Given this list of marker genes Mc4r, Zwint, Kif13a, Osmr, S100b, Serinc1 (serine incorporator 1, NCBI Gene Id 80452), Zfp704, Egflam, Copb1, Rcan2, Hhipl2, Grb2, Vti1a, Rhag, Fchsd1, Pafah1b1, Eif2ak4, Tnrc6a, Slc39a13, Hspa4l, Thsd7a, Actr1a, Med22, Mettl9, Atp5f1a, Tafa3, Alkbh5, Plaa, Arid1a, Ncbp3, Map3k9, Mapk6, Smdt1, Wtap, Raph1, Srsf2, Dnm1, Crtc1, Dis3l, Lhx3, Cabin1, Rbm27, Sh2d7, Ranbp10, Fndc10, Nsd2, Wdhd1, Tceal7, Tgm3, Pgbd5, Sstr1, Eif5, Slc25a42, Rtel1, D5Ertd579e (NCBI Gene Id 77811), Rccd1, Kcnk3, Cpt1a, Cdo1, Alx3, Cdh5, Mgat4a, Nol3, Tube1, Crebrf, Plxna1, Rubcn, Cant1, Ncor1, Frs3, Zeb2, Prr11, Lias, Vhl, Slc24a3, Shisal1, Ak1, Dgkg, Hivep3, Vcp, Gpatch4, Cdc26, Ndufa8, Krtap5-3, Trip12, Pde4d, Galnt16, Fkbp1a, Elavl1, Brdt, here is a description of the gene set: studied in species Mus musculus from publication Chen Y, Wang X (PMID 31504780) Mouse Gene Set: MIR_12188_3P Genes predicted to be targets of miRBase v22 microRNA mmu_miR_12188_3p in miRDB v6.0 with MirTarget v4 prediction scores > 80 (high confidence targets).